Given this list of marker genes POLR3F, SNAPC4 (NCBI Gene Id 80189), BDP1, POLR3D, POLR3C, POLR2L, POLR2H, POLR2K, SNAPC5, POLR2F, SNAPC1, POLR3GL, TBP, BRF2, POLR3K, POLR3A, POLR3H, POLR3E, POLR3G, POLR1D, ZNF143, POLR1C, POLR3B, SNAPC2, POU2F1, POLR2E (NCBI Gene Id 5434), SNAPC3, CRCP, here is a description of the gene set: Reactome Pathway: RNA Polymerase III Transcription Initiation From Type 3 Promoter The metazoan-specific type 3 promoters, which are exemplified by the human U6 promoter, recruit a complex variously called the snRNA activating protein complex (SNAPc), the PSE binding protein (PBP), or the PSE transcription factor (PTF). The complex contains five types of subunits and binds to the PSE. Type 3 promoters also recruit Brf2-TFIIIB through a combination of protein-protein contacts with SNAPc and a direct association of the TBP component of Brf2-TFIIIB with the TATA box. This then allows RNA polymerase III to join the complex.<p>The down stream element (DSE) of type 3 promoters, which enhances transcription from the core promoter, almost invariably contains an octamer sequence and an SPH element (also called NONOCT element). The octamer sequence recruits the POU domain protein Oct-1, and the SPH element recruits a zinc finger protein known as Staf or SPH binding factor (SBF), which has been cloned from humans. species: Homo sapiens part of: RNA Polymerase III Transcription Initiation